Given this list of marker genes SPARC, ITGAV, CTSZ, MYL12B, OSTC, NORAD, PSMA4, PDGFRA, MDK, MEG3, CTSB, COL1A1, FZD1, COL5A2, CHPF, MMP23B, COPS9, COL8A2, VAMP5, DKK3, THBS3, UGCG, ECM2, CSRP1, EMILIN1, SLC44A1, FSTL1, LTBP2, LAMB1, PDLIM2, ABI3BP, TTC3, FAM118A, YIF1A, SELENOF, FLNA, CERCAM, MRC2, MFAP4, GAS6, SEC31A, COTL1, FKBP10, FOXP1, FKBP11, HCFC1R1, FKBP9, FKBP7, FBN1, EFEMP2, COL16A1, SSR3, SPON1, KIAA1217, SSC5D (NCBI Gene Id 284297), SEC24D, FRMD6, GRN, FGF7, CREB3L1, NUCB2, RRBP1, RABAC1, CYBRD1, P4HA3, SERF2, NDUFS6, MT-ND2, DAB2, CKAP4, RCN3, NDUFA4, PTGFRN, CFH, VCAN, FAM114A1, LRRC15, LRP1, IFT20, SEC61A1, TENT5A, ADAMTS2, SMCO4, MFAP5, OST4, SPATS2L, LSM7, UROS, GAS1, GOLM1, COL5A1, GPX7, PDLIM7, P3H3, P3H4, SSR1, TMED3, C1orf122, NFIX, ISOC2, CCDC3, FGGY, GPX8, RTL8C, FAM3C, ID3, FNDC1, SEC61B, MAP4K4, TM9SF3, C1QTNF6 (C1q and TNF related 6), CPXM1, EGFL6, IL1R1, FAP, TMEM167A, GPX4, CCDC80, PLEC, GOLM2, NME4, CTSA, LMCD1, ADAM12, COL14A1, TIMP2 (TIMP metallopeptidase inhibitor 2), PTN, P3H1, CDH11, CNN2, PYCR1, JTB, CYP1B1, WFDC1, MAGED1, TGFBR1, CRELD2, GLS, TAX1BP3, SFRP2, LAMTOR2, EMID1, ITGB5, CD9, PPIB, FHL2, FBLN1, RCN1, KDELR2, MARVELD1, RAC3, ERLEC1 (NCBI Gene Id 27248), GLIPR2, SDC1, PTX3, MPZL1, here is a description of the gene set: from publication Su Z, Ho JWK, Yau RCH, Lam YL, Shek TWH, Yeung MCF, Chen H, Oreffo ROC, Cheah KSE, Cheung KSC (PMID 38267611) Identified by extracellular matrix organization and collagen fibril organization, with markers like COLIA1/Collagen I, COL3A1, and VCAN. The transformation of benign lesions to malignant tumours is a crucial aspect of understanding chondrosarcomas, which are malignant cartilage tumours that could develop from benign chondroid lesions. However, the process of malignant transformation for chondroid lesions remains poorly understood, and no reliable markers are available to aid clinical decision-making. To address this issue, we conducted a study analysing 11 primary cartilage tumours and controls using single-cell RNA sequencing. By creating a single-cell atlas, we were able to identify the role of endoplasmic reticulum (ER) stress in the malignant transformation of conventional central chondrosarcomas (CCCS). Our research revealed that lower levels of ER stress promote chondrosarcoma growth in a patient-derived xenograft mouse model, while intensive ER stress reduces primary chondrosarcoma cell viability. Furthermore, we discovered that the NF-?B pathway alleviates ER stress-induced apoptosis during chondrosarcoma progression. Our single-cell signatures and large public data support the use of key ER stress regulators, such as DNA Damage Inducible Transcript 3 (DDIT3; also known as CHOP), as malignant markers for overall patient survival. Ultimately, our study highlights the significant role that ER stress plays in the malignant transformation of cartilaginous tumours and provides a valuable resource for future diagnostic markers and therapeutic strategies. Human Gene Set: SU_HO_CONV_CENT_CHONDROSARCOMA_STROMAL_C4_CANCER_ASSOCIATED_FIBROBLAST studied in species Homo sapiens